Given this list of marker genes Dis3, Slfn8, Exosc4, Exosc7, Pelo, Ddx49, Slfn9, Exosc8, Exosc5, Xrn1, Dis3l (DIS3 like exosome 3'-5' exoribonuclease), Exosc6, Trir, Slfn14, Ern2, Exosc9, here is a description of the gene set: species: Mus musculus The chemical reactions and pathways resulting in the breakdown of rRNA, ribosomal RNA, a structural constituent of ribosomes. Mouse Gene Set: GOBP_RRNA_CATABOLIC_PROCESS